Given this list of marker genes CEBPE, TET2, TMEM147, LBR, NBAS, SF3B1, here is a description of the gene set: Human Gene Set: HP_HYPOSEGMENTATION_OF_NEUTROPHIL_NUCLEI species: Homo sapiens Hyposegmentation of neutrophil nuclei Hyposegmented (hypolobulated) or bilobed neutrophil nuclei.